The following is a description of a gene set: Enables the transmembrane transfer of an ion by a channel that opens when a specific extracellular ligand has been bound by the channel complex or one of its constituent parts. studied in species Homo sapiens Human Gene Set: GOMF_EXTRACELLULAR_LIGAND_GATED_MONOATOMIC_ION_CHANNEL_ACTIVITY, and this is the list of marker genes: GLRA3, GABRG1, P2RX5, GRIK2, CHRNA6, GRIK3, GLRB, P2RX6, SLC1A7 (solute carrier family 1 member 7), GABRR1, GABRA2, P2RX3, HTR3E, HTR3D (NCBI Gene Id 200909), GABRA4, CHRNA10, CHRNB1, CHRNE, CHRNA9, TRPV1, GRIN3A, CHRNA7, CHRNA2, HTR3C, GRIN1, GABRA1, GABRB3, GRIN2D, GABRG3, CHRNB4, GABRG2, GABRB1, GRIN2A, GRIN3B, P2RX1, CHRNB3, GRIA2, GRIN2C, GRID2, HTR3A (5-hydroxytryptamine receptor 3A), GLRA1, GABRA5, GABRB2, GABRR3, CHRNB2, GRIA1, GRIK1, GABRA6, GRIK4, GABRE, CHRNG, SLC17A7, GRIA3, CHRNA3, CHRNA5, GABRR2, GRIA4, P2RX2, CHRNA4, CHRND, GRID1, GLRA2, GABRA3, ZACN (zinc activated ion channel), HTR3B, P2RX4, P2RX7, GRIN2B, GRIK5, GABRD, CHRFAM7A, GABRQ, CHRNA1, GABRP